The following is a description of a gene set: Neighborhood of USP6 ubiquitin specific peptidase 6 (Tre-2 oncogene) in the GCM expression compendium Neighborhood of USP6 species: Homo sapiens Human Gene Set: GCM_USP6, and this is the list of marker genes: MTCH2, FAN1, GFM2, RIPK1, GLYCTK, SMG5, FBXL20, SCAMP2, OTUD6B, PRDM4, VPS53, DDX11, SIN3A, ATG4B, CNPPD1, TUT1, EPS15L1, HAPSTR1, SNAPC3, COQ10A, RMND5B, KLHL17, IRAG1, FAM81A, MKS1, SH2B1, ZNF672 (zinc finger protein 672), GIGYF1, SEC24A, PEX11B, CS, TMEM138, KPNA6, TBC1D22B, IPO5, ATP2B2, KRT85, GGT7, TEX261, LRIG2, DIP2B, COG5, SEMA4F, EDNRA, DHX37, USP6, KLHL18, COPS7A, EVI5L, DENND4A, TMEM254, ISCA1, URGCP, BOD1L1, TADA2B, VCP, BAHD1, ERAL1, POLR2M, DHRS11, ADD2, AP2A1, FAM167A, MTMR7, TMX3, MYO9A, ACAD11, DNAJC27, TBC1D10B, MMP16